The following is a description of a gene set: studied in species Homo sapiens Human Gene Set: MIR449A from publication Chen Y, Wang X (PMID 31504780) Genes predicted to be targets of miRBase v22 microRNA hsa-miR-449a in miRDB v6.0 with MirTarget v4 prediction scores > 80 (high confidence targets)., and this is the list of marker genes: RAP1GDS1, DMWD, GABRA3, FAM83A, RAB21, PDGFRA, ZDHHC17, FRA10AC1, DPP3, CACNB3, TPCN2, AMER1, ACSL4, PPARGC1B, GP5, ASIC2, E2F3, GPR22, CNOT6, OSGIN2, DNAJC16, EPHA4, PACS1, PPP1R16B, RGS17, PRKD1, SCN2B, ZDHHC16, ASB1, ZNF16, RALGPS1, ADD2, COL26A1, MYH9, ASB4 (ankyrin repeat and SOCS box containing 4), WIPI2, TMEM109, MEX3C, ANK3, TMEM79, SYT1, TMEM200B, FAM167A, ESYT3, PPP2R3A, CUEDC1, VCL (vinculin), ANKS1A, SIDT2, ZYG11B, RELN (reelin), NOS1AP, INA, AKIP1 (A-kinase interacting protein 1), SLC25A27, FKBP1B, RPGRIP1L, RTL6, TASOR, PDXK, GLCE, ARHGAP1, BMP3, FLOT2, LILRA1, PPP1R10, TGIF2, NOTCH2, KDM5D, RFX3, TOB2, DCAF7, XYLT1, LGR4, TAF4B (TATA-box binding protein associated factor 4b), HSPA1B, ZBTB9, OLIG3, RTN4RL1, FOXJ2 (forkhead box J2), NUMBL, USP31, NRN1, SLC4A7, TRANK1, ELMOD1, IL6R, SNX15 (NCBI Gene Id 29907), DLL1, ARHGAP26, SATB2, RAD9B, ZFHX4, PEA15, TSN, JAKMIP1, SRPRA, TNRC18, ABR, CNTN2, RPS6KL1, EML5, SHOC2, PAX5 (NCBI Gene Id 5079), RPS6KA4, LHX2, FAM107A, SEPTIN3, FRMD5, ZNF644, RRAGC, TMEM184B, PKP4, TMEM74, NOTCH1, POGZ, SAR1A, CDH9, ZNF304, S1PR3, FBXO30, CBFA2T3, LDHA, SHISA7, ANK2, SYNJ1, MET, CACNA1C, BRPF3, CTNND2, ZMYND11, SMAD4, FOXN2, PPM1A, CREB3L2, SLC37A3, TAF5, AHCYL2, BRINP1, UBP1, ADAM22, SLC44A2, MDM4, ERC1, DAAM1, SNX9, CDK6, ZMYM4, SIDT1, LMAN1, EPN2, FOXP1, PNOC, RRAS, YTHDC1, ARID4B, UNC13C, SFT2D1, LIN28B, JADE2, BNC2, TRIM67, RTL8A, MAP7D3, SURF4, SHKBP1, SEMA4B, FUT9, AXL, ACSL1, SNTB2, CAMTA1, LYST, CAMK4, CERS6, ADO, GOLPH3L, PURB, TMEM164, IGF2BP3, SGTA, CDC25A, GREM2 (gremlin 2, DAN family BMP antagonist), CYREN, FGF23, ALG13, MGAT5B, KCNK3, E2F5, GMNC, MYT1, PLAG1 (PLAG1 zinc finger), CCNE2, NCDN, CLCN3, MTCL2, LIMD2, CELF3, FUT8, PLOD1, NAV1, ELL2 (elongation factor for RNA polymerase II 2), PPFIA1, PEG10, NRIP3, TBCK, STAB2, OAZ2, HCN3, GALNT7, SNAI1, RDH11, DNM1L, FAM117B, C14orf28, STX17 (NCBI Gene Id 9485), HTR2C, TPD52, ANP32A, MMAB, MTMR10, ZNF551, XBP1, NAV3, TANC2, DIXDC1, TBL1XR1, XPO5, GPR158, TENT5A, ZNF281, MYCN, SGPP1, SSX5, MBLAC1, SLC27A4, GAS1, GINS3, MCIDAS, ATMIN, ABTB3, TMEM255A, VAMP2, EPS15L1, FAM76A, ATG4B, ATG5, CBX3, CHM, ERGIC1, CDH13, KLF4 (KLF transcription factor 4), DGKZ, PDE7B, CPLX2, RCAN1, DPYSL4, CACNA1E, ARHGEF33, MAP2K1, ACBD3, THSD4, MGAT4A, MLLT3, PPP1R11, BCL2L13, CLOCK (clock circadian regulator), ANKRD52, LMAN2L, TPPP, PTGIS, SNX12, LEF1, SUCO, MPP2, ZBTB20, STRN3, DAGLA, METAP1, NCEH1, PITPNC1, JAG1, CA7, SMIM15, ADIPOR2, NECTIN1, WASF1 (WASP family member 1), SDK2, FGD6, PLEKHH2, NPNT, PGM1, HNF4A, ALDOA, AGO4, STK38L, SERPINF2, CDH4, GMFB, UCN2, CA10, CAPN6, ABCD1, KITLG, MLLT1, KIAA1217